The following is a description of a gene set: The synthesis of 5S ribosomal RNA (rRNA), or an equivalent rRNA, from a DNA template by RNA polymerase III (Pol III), originating at a type 1 RNA polymerase III promoter. Human Gene Set: GOBP_5S_CLASS_RRNA_TRANSCRIPTION_BY_RNA_POLYMERASE_III studied in species Homo sapiens, and this is the list of marker genes: GTF3C2, GTF3C4, GTF3C3, GTF3C5, GTF3C1, GTF3C6